The following is a description of a gene set: Human Gene Set: HP_GRANULOMA A compact, organized collection of mature mononuclear phagocytes, which may be but is not necessarily accompanied by accessory features such as necrosis. Granuloma species: Homo sapiens, and this is the list of marker genes: ACP5, IRF8, DOCK2, DNASE2, PIK3CG, NF1, CYBB, CYBC1